The following is a description of a gene set: studied in species Mus musculus electronically inferred by orthology from the curated human pathway part of: DNA Damage Bypass Reactome Pathway: Recognition of DNA damage by PCNA-containing replication complex This event has been computationally inferred from an event that has been demonstrated in another species.<p>The inference is based on the homology mapping from PANTHER. Briefly, reactions for which all involved PhysicalEntities (in input, output and catalyst) have a mapped orthologue/paralogue (for complexes at least 75% of components must have a mapping) are inferred to the other species., and this is the list of marker genes: Cul4b, Pole2, Rfc1, Pold4, Dtl (NCBI Gene Id 76843), Pold1, Rps27a (NCBI Gene Id 78294), Pole, Cul4a, Pold2, Ddb1, Ubb, Wdr48, Rpa1 (replication protein A1), Rfc3, Usp1, Pcna